The following is a description of a gene set: studied in species Homo sapiens Human Gene Set: GOBP_MEMBRANELESS_ORGANELLE_ASSEMBLY The aggregation, arrangement and bonding together of a set of components to form a non-membrane-bounded organelle., and this is the list of marker genes: TIA1, PIBF1, TUBGCP4, ZFYVE1, MIS12, SAC3D1, MAP10, CETN2, KRT19, RPS28, RHO, PATL1, MAPT (microtubule associated protein tau), VPS4B, GTF2B, LMOD2, MYPN, EIF6, FXR1, MTERF3, OFD1, NKX2-5, MYH6, ABRAXAS2, CEP72, RPF2, CCDC78, RPS14, CENPA, CHMP4BP1, SQSTM1, NIP7, WNK1, CENPK, CEP152, CENPJ, MYLK3 (NCBI Gene Id 91807), TNNT2, TNRC6A, EDC3, MZT1, CCDC61, BRIX1, DAZAP2, MYBL2, TUBB, CHMP1A, SKA1 (spindle and kinetochore associated complex subunit 1), RPL5, PWP2, LSM3 (LSM3 homolog, U6 small nuclear RNA and mRNA degradation associated), TNF, C1QBP, WASHC5, LIAT1, DDX6, PAN3, RRS1, FSCN1, VCX, DRG1, SPAG5, MYH3, PRKD1 (NCBI Gene Id 5587), NEK2, RPL38, ACTC1, AURKC, TNNT1, TPR, CCSAP, CDC20, HAUS8 (NCBI Gene Id 93323), MCIDAS, CHMP2A, NDC80, MYL2, ANG, SRC, MYOZ1, FMR1, TMOD4, LZTS2, MAPK15, MCAT, YTHDF1, MYOM3, XRCC5, MTERF4, ASPM, RPSA2, RPL10L, ACTN2, BRCA1, KAT2A, TTN, UBAP2L, PRKDC, DDB1, SASS6, TUBB1, SYNPO2L, PRC1, STARD9, MYH11, CHMP7, STAG2, ATG5, POC1B, MYH10, EFL1, BMP10, RC3H1, ATXN2, HSF1 (NCBI Gene Id 642255), HDAC3, KIF3B, CDK2, KASH5, SENP6, RBM14, RPS15, ABRAXAS1, OGFOD1, CSDE1, NRAP, RNF4, STIL, TCAP, SMC1A, CEP44, SQLE, PRKAR1A, METTL17 (methyltransferase like 17), FUS, WRAP73, DHX37, CNOT7, CHMP2B, CIRBP, G3BP2, DHX30, C10orf90, NCOR1, FLNA, CFLAR, MYBPC2, MYOM1, FARP2, MAPRE2, CHEK2, CSF2, MAPRE1, RPS27L, SRF, CHMP6, KIF2A, GOLGA2, SMC3, MOSPD2, RCC1, NEBL, NOA1, DCAF13, PATL2, CSRP1, GRB7, SKA2, HCK, EDN1, TUBGCP2, KLHL41, RPS3, YTHDF2, PPP2R1A, MYBPH, CHMP4B, DYNC1H1, PTEN, CEP63, CEP76, ZNF207, PPP2R1B, DEUP1, CDK5RAP2, PPP1R35, WNK3, HAUS7, AGO2, MPV17L, RRP7BP, PRKAA2, NBDY, EIF2A, ITGB1, LDB3, PSPC1, CENPF, PLK1, USP10, IL5, KIFC1, NEK7, EIF4ENIF1, SUGT1, EZR, STAG1, CAPN3, DIAPH3, LIMD1, LSM14B, CEP97, TNNT3, KIF4B, MRPS2, PDCD6IP, KIF23, KNTC1, ALMS1, MEF2A, TPX2, HAUS1, AAAS, CENPH, PROX1, JMJD6, OBSCN, RPSA, MPV17L2, SPICE1, SMAD4, AR, POLDIP2, SBDS, MYL9, ANLN (NCBI Gene Id 54443), CHMP4C, LCP1, BCCIP, BOP1, PRRC2C, CCDC15, TMOD1, WDR62, WDR90, AURKA, KIF4A, HAUS3, PDGFRB, TNKS, MTG1, RNF213, MYOZ2, UHRF1, CETN1, CSRP3, CNOT1, OBSL1 (NCBI Gene Id 731094), LMOD1, PLK2, KIF9, HAUS5, TUBGCP3, LSM4, MIR1-1, CNTROB (NCBI Gene Id 116840), C9orf72, SYT1, CAPG, EML3, ARHGEF5, GPSM2 (G protein signaling modulator 2), FBXO5, CFL2, POC5, CENPX, NEGR1, MDM1, CHMP4A, RPS27, EIF1AX, CEP295NL, MYBPC3, MAPK9, CNOT2, SIX4, PDGFRA, CDS2, BCAS2, CDC20B, SH3PXD2B, YTHDF3, ACTA1, MAP9, RTTN, HAUS2, RPS19, NPM1, MRTO4, BIRC5, KIAA0753, VIL1, TPM1, FLII, CEP135, TUBB8, PLS1, GSN, PLK4, ADPRHL1, AKAP13, CCDC57, DLGAP5, CDCA8, NOP2, SKA3, PISD, NEB, NOP53, RACGAP1, CHMP3, BSCL2, RPS23, LSM14A, CEP120, INCENP, CLASP2, BICD1, NOCT, RIPOR2, TUBGCP6, ZAR1, TMOD2, TRIM37, TRAPPC12, CCDC69, CAPRIN1, DOCK5, MSN, SEPTIN1 (septin 1), FLNC, HSPA1B (heat shock protein family A (Hsp70) member 1B), ACTG1, TMOD3, EIF5, EIF2S1, BECN1, HAUS4, CEP192, ARHGEF10, NGRN, KPNB1, MISP, CCP110, CNOT6L, DHX29, ATXN2L, MLH1 (mutL homolog 1), RPL11 (ribosomal protein L11), MDN1, HSPA1A, CSRP2, ERAL1, CLASP1, CEP295, CENPT, MYOM2, FITM1, MTG2, PGM5, CDS1, C2CD3, RPL24, RAB11A, FAU, AURKB, PRICKLE1, ALKBH5, ABT1, PRKAA1, G3BP1, FITM2, MRPS7 (NCBI Gene Id 64967), DBNL, KIF15, TUBGCP5, HAUS6, CAV3, WDR1, NEK6, CENPC, MYBPC1, RRP7A, NUMA1, CNOT6, MAPRE3, ANKRD1, KAT2B, STYXL1, E2F4, LMOD3, CHMP5, DDX28, EIF5B, HNRNPU, FASTKD2, RCC1L, LDAF1 (lipid droplet assembly factor 1), RPS5, CEP85, FHOD3, KIF11, CHMP1B, BIN2, ANKRD23, SMIM22, PUM2, PLEC, NUP62, POGZ (NCBI Gene Id 23126), PLA2G4C, RANGRF, CCDC66, PAN2, RPS6, CASQ1, ASB2, INO80, CENPW, CCNB2, CSNK1D, RHOA, AUP1, MIURF, DDX3X, MRM2, CENPE